The following is a description of a gene set: Enhanced secondary Ab responses are a vital component of adaptive immunity, yet little is understood about the intrinsic and extrinsic regulators of naive and memory B cells that results in differences in their responses to Ag. Microarray analysis, together with surface and intracellular phenotyping, revealed that memory B cells have increased expression of members of the TNF receptor, SLAM, B7 and Bcl2 families, as well as the TLR-related molecule CD180 (RP105). Accordingly, memory B cells exhibited enhanced survival, proliferation and Ig secretion, as well as entered division more rapidly than naïve B cells in response to both T-dependent and T-independent stimuli. Furthermore, both IgM and isotype switched memory B cells, but not naïve B cells, co-stimulated CD4+ T cells in vitro through a mechanism dependent on their constitutive expression of CD80 and CD86. This study demonstrates that upregulation of genes involved in activation, co-stimulation and survival provides memory B cells with a unique ability to produce enhanced immune responses and contributes to the maintenance of the memory B cell pool. Genes up-regulated in comparison of naive B cells versus memory B cells. studied in species Homo sapiens from publication Good KL, Avery DT, Tangye SG (PMID 19124732) Human Gene Set: GSE13411_NAIVE_VS_MEMORY_BCELL_UP, and this is the list of marker genes: SPAG11B, DHFRP3, PLK4, KLHL29, CD40, SNAP91, SNTG2, INA, B9D2, ADAMTS6 (ADAM metallopeptidase with thrombospondin type 1 motif 6), CRYBB2, RBMS2, GRB14, MORC1 (NCBI Gene Id 27136), BHLHE40, MIR600HG, TRIM58, ADARB2, MYEF2, PALLD, NQO1, ASGR2, BRINP2, PLCB3, SLAMF1 (signaling lymphocytic activation molecule family member 1), IL3RA, HIPK3, MAGEB3, DAZL, CT55, SLCO1C1, TRGV5, CD8B, EFNB3, ZNF444, H1-0, MFAP3L, GJA4 (NCBI Gene Id 2701), ANKRD36BP2, RASSF9, SPRING1, LIG3 (NCBI Gene Id 3980), BGN, ZPBP, ADAM7, SYT11, SEZ6L, BCO1, SCGN, CAMK2A, TRIM36, CCDC82, ADCY10, GDPD3, SVIL, SYNE3, RIMS1, AP4E1, MACIR, TSC22D3, LIFR, WDHD1, ZNF155, HTR1F, OR7A5, DGKI, C3orf52, CHN2, SNAI2, ARHGAP44, CEP162, ZNF473, ZNF446 (zinc finger protein 446), SCGB1D1 (secretoglobin family 1D member 1), ANKRD1, ZNF606, GABRB3, GNRHR, RDX, NAV3, CRISP2, JRK, COL3A1, VIPR2, CCT8L2, IL1RAPL1, RPS16, SOX30, GRM6, VGLL3, NELFA, MAPKAPK5-AS1, GOLGA6A, MOCOS, USP9Y, EPHA4, RPRM, CD72, NXPH4, KYAT1, MMP26, CASK, HMGA2, WDR76, CADM4, CPB1, ZBED2, ABCA6, JPH2 (NCBI Gene Id 57362), RASGRF1 (Ras protein specific guanine nucleotide releasing factor 1), BBS9, ANO2, STMN3, PTPRJ, SEMA6D, FBXL2, FRZB, KIF4A, PTPN21, PCDHB12, SYN2, SYNJ1, LGR5, MYCT1, FAM124B, CORIN, MCM10, RAI14, KLF3, IL12B, NEB, ZNF395, CORO1A, CEACAM8, CHST5, ART4, CHI3L1, FLT3, KCND3, TNIK, INPP5J, OR7E36P, NES, NPHS2, MEIS2, EIF5A2, LINC01587, MAGEA8, PPP1R13L, ADH7, NCKAP1, APOA2, EPHB1, LINC00667, STS, LCT, NAT8B, GSDMB, SPC25, AKR1C3, CRYBA4, PMF1, STAG3L4, CDADC1, OVOL2, NDST3, GHRH (NCBI Gene Id 2691), IQCH, PDZRN4, SLCO1B3, CORO2B, IFNG, PCSK1, ZNF154, RUNX2, VAX2, DCUN1D4, ZFPM2, FLG, PDZK1, NTRK2, SLC6A6, MGC4859, SNRPN (NCBI Gene Id 6638), ZNF440, ZNF507, SORBS2, ADAMTS5, CEP112, GAGE1 (NCBI Gene Id 2543), TAS2R9, AFF4